Given this list of marker genes Ghrl, Uts2r, Gabrb3, Uts2, Pmch, Chrnb2, here is a description of the gene set: Mouse Gene Set: GOBP_CIRCADIAN_SLEEP_WAKE_CYCLE_REM_SLEEP studied in species Mus musculus A stage in the circadian sleep cycle during which dreams occur and the body undergoes marked changes including rapid eye movement, loss of reflexes, and increased pulse rate and brain activity.